The following is a description of a gene set: studied in species Homo sapiens from publication Busslinger GA, Weusten BLA, Bogte A, Begthel H, Brosens LAA, Clevers H (PMID 33691112) Human Gene Set: BUSSLINGER_ESOPHAGEAL_DENDRITIC_CELLS, and this is the list of marker genes: VASP, EVI2B, HSPA1A, SPI1, RUNX3, FOS, INSIG1, HLA-B, TMSB4X, RGS1, ADCY7, ADA2, TMSB10, DPYSL2, YWHAH, TIMP1, CSF1R, RBPJ (recombination signal binding protein for immunoglobulin kappa J region), PLAUR, ALOX5, LGALS1, DENND1B, HLA-DRB1, CD74, CNN2, HLA-DQA1, PTGS2, LSP1, CFP, RASSF2, LTB, HLA-DPA1 (major histocompatibility complex, class II, DP alpha 1), C15orf48 (chromosome 15 open reading frame 48), MPEG1, MYADM, SLA, HLA-DQB1, HLA-DQB2, RAP1A, SEPTIN6, CXCL16 (NCBI Gene Id 58191), CAMK1D, CSF2RB, NR4A3, PTPRC, VIM, GLRX, MAFF, DUSP2, EHBP1L1, CNTRL, IL1B, SERPINF1, STK17B, INPP5D, S100A4, CD37, CCND2, MAPRE1, ANKRD44, SKIL, RGS10, UCP2, GPR183, CACNA1G, CELF2, CFL1, JUND, B2M, IFI30, AXL, SLC18A2 (NCBI Gene Id 6571), CRIP1, TACC1, MAN2B1, HLA-DMA, NR4A1, CD207, LMNA, SH3KBP1, TUBA1B, MIDN, CD1E, CLDN1, PXDC1, JUNB, MAP3K2, ARHGDIB, ARPC1B, SH3BGRL3, PAK1, SLC12A7, TXNIP, GNA15, FCGRT, LAPTM5, NDRG2, ACTR2, JAML, CHAD, SLC29A1, PLEK, ITGAX, NR4A2, ATP2B1, ANXA5, GRK3, HIP1, CD1C, NFATC2, LST1, IL13RA1, CLEC5A, GSN, PNRC1, NIBAN1, HLA-DRA, CD83, TNFAIP3, PTMS, VOPP1, LYN, ZNF331, BAIAP2, ATP6V0B, PFN1, RASSF5, SLC2A1, FGL2, CCNI, ACTB, HCK, CDYL, NAP1L1, SERPINB9, PTP4A2, S100B, CD4, CMTM6 (NCBI Gene Id 55487), GNAI2, PKIB, PRKCB, RGS2, HLA-DRB6, MAP2K1, PEA15, CYRIB, LCP1, FOSB, GNB1, MS4A6A, RYBP, HLA-DPB1, ITGB2, PPT1 (palmitoyl-protein thioesterase 1), PER1, GPX1, CYBB, ADAM8, PLEK2, ALOX5AP, CD1A, SGK1, ZMIZ1, MOB3A, PTK2B, FCGBP, SYNGR2, ARL4C, FCER1A, BASP1, IL2RG (interleukin 2 receptor subunit gamma), ZFHX3, CTSS, CAP1 (NCBI Gene Id 10487), CPVL, CD52, CST3 (cystatin C), CTSH, ENG, TAMALIN, LITAF, RAB5C, SRGN, HLA-DMB, ZFP36 (NCBI Gene Id 7538), TMEM14C, COTL1 (coactosin like F-actin binding protein 1), FTL, GDI2, IER5, CCDC88A, ALCAM, CKLF, ZYX, ENTPD1, YPEL5, KDM6B, TBC1D4, RANBP2, ABCC3, AIF1, CD86, FTH1, HLA-DOA, SLC2A3, RHOG, PDE4A, TYROBP, MACROH2A1, CLEC10A, FXYD5, HLA-DRB5, PARM1